The following is a description of a gene set: Mouse Gene Set: GOBP_REGULATION_OF_PROTEASOMAL_UBIQUITIN_DEPENDENT_PROTEIN_CATABOLIC_PROCESS studied in species Mus musculus Any process that modulates the frequency, rate or extent of the breakdown of a protein or peptide by hydrolysis of its peptide bonds, initiated by the covalent attachment of ubiquitin, and mediated by the proteasome., and this is the list of marker genes: Sh3rf1, Rack1 (receptor for activated C kinase 1), Usp7, Pias1, E330034G19Rik, Sirt6, Sumo2, Zer1, Wnt10b, Csnk1a1, Bag6, Atg7, Pbk (PDZ binding kinase), Phf20l1, Csnk2b, Commd1, Nub1, Trib2, Shh, Foxf2, Rad23a, Cbfa2t3, Fbxo22, Pabir1, Rbx1-ps, Plk3, Dnajb2, Rchy1, Clu, Chfr, Usp9x, Map1a, Hspa1a, Ube2k (ubiquitin-conjugating enzyme E2K), Hfe, Gna12, Sirt2, Gabarap, Clec16a, Csnk1d, Socs4, Akt1, Tlk2, Smarcc1, Ufl1, Hsp90ab1, Rybp-ps, Pabpn1l, Uchl5, Bag2, Trf, Rbx1, Dda1, Gsk3a, Gba1, Cop1, Taf9, Eif3h, Park7, Ccar2, Bag5, Dab2, Gipc1, Lrrk2, Mapk9, Prkn, Nkd2, Paqr3, Nop53, Fbxw8, Usp38, Styx-ps, Plk2, Mdm2, Fzr1, Axin1, Mapk8, Mtm1, Styx, Aurka, Axin2 (NCBI Gene Id 12006), Usp26, Dvl1, Prickle1, Stub1, Trib3, Hspa1b, Vcp, Psmd10, Ddrgk1, Sumo1, Psen1, Sh3rf2, Cdc20b, Rpl11, N4bp1, Desi1, Rybp, Det1, Gsk3b, Klhl40, Zfp418, Xpo1, Senp1, Trim39, Gclc, Zfand2a, Il33, Bbs7, Ogt, Ubqln4, Hspbp1, Csnk1e, Fhit, Plk1, Sh3rf3, Csnk2a2, Rnf180, Psen2 (NCBI Gene Id 98295), Ubxn1, Cdc20, Socs5, Trib1, Zyg11b, Wac, Caml, Glmn, Ube2v2, Ttc36, Araf, Rad23b, Usp5, Sirt1, Hamp